Given this list of marker genes Entpd4, Pals2, Nudt18, Entpd4b, Pals1, Guk1, here is a description of the gene set: studied in species Mus musculus Mouse Gene Set: GOBP_GDP_METABOLIC_PROCESS The chemical reactions and pathways involving GDP, guanosine 5'-diphosphate.